Given this list of marker genes Ebf2 (NCBI Gene Id 13592), Parp9, Gmnn, Dtx3l, Ctbp2, Ddx11, Cdt1, Kdm4d, Zfp618, Med25, Tunar, Pygo2, here is a description of the gene set: studied in species Mus musculus Any process that increases the frequency, rate or extent of chromatin binding. Chromatin binding is the selective interaction with chromatin, the network of fibers of DNA, protein, and sometimes RNA, that make up the chromosomes of the eukaryotic nucleus during interphase. Mouse Gene Set: GOBP_POSITIVE_REGULATION_OF_CHROMATIN_BINDING